The following is a description of a gene set: Neighborhood of BUB1 BUB1 budding uninhibited by benzimidazoles 1 homolog (yeast) in the MORF expression compendium Neighborhood of BUB1 studied in species Homo sapiens Human Gene Set: MORF_BUB1, and this is the list of marker genes: RRM1, VDAC1, EI24, HAT1, XPOT, CYCS, NUDC, SPAG5, YARS1, IARS1, PPP1CC, VBP1, DLGAP5, TFDP1, PMEL, MRPS18B, KHSRP, TYRO3 (NCBI Gene Id 7301), ZWINT, RFC4, KIF14, SRSF1, IMMT, MTREX, GARS1, BUB1B, RFC3, TPX2, FOXM1 (NCBI Gene Id 2305), USP1, MFAP1, KIF2C, NSD2, HMMR, HDAC2, HDDC2, KIF11, BUB3, CCNB1, GOT2, CCT5, ATP5PO, PLK1, SSBP1, NDC80, BAZ1B, TARS1, MCM6, BUB1, ESPL1, H2AZ1, SRPK1